The following is a description of a gene set: Genes predicted to be targets of miRBase v22 microRNA hsa-miR-4728-3p in miRDB v6.0 with MirTarget v4 prediction scores > 80 (high confidence targets). Human Gene Set: MIR4728_3P species: Homo sapiens from publication Chen Y, Wang X (PMID 31504780), and this is the list of marker genes: RORA, SMCHD1, ZNF655, KLHL2, SAMD12, PHLPP1, ZNF148, PTBP3, DMAC1, BDP1, PTCH1, PICALM, CNN3, GRM5, KICS2, SNX17, ZFP90, PRP4K, GPC6, ZSWIM6, PLXNA4, TRAM1, RAB6C, KCNA1, RYBP, TFPI, SEL1L, ZFAND5, HS3ST2, SCN1A, LRRN3, PABIR1, CDK19 (cyclin dependent kinase 19), GABRB3, OCIAD1, ZCCHC12 (zinc finger CCHC-type containing 12), UBE2K, TLL1, NDUFA2, NCOA1, ARMC2, CAB39, ZNF367, YWHAE, RALBP1, AMPD3, STK26, PGRMC2 (NCBI Gene Id 10424), ATPAF1, BTF3L4, SLC26A8, AMMECR1, KMT5B, TMED10, CACNA2D3, NCOA7, SLC9A6, SNX13, KRTAP7-1, CIDEB, CDIN1, FAM149B1, EMSY, CNOT4, MCHR2, MAPK1, PAK3 (NCBI Gene Id 5063, p21 (RAC1) activated kinase 3), ZNF189, LPP, KCNB1, TAF4, PPARGC1A, PRKACB (NCBI Gene Id 5567), GLCCI1, TNIP3, RABL2B, ZSCAN16 (NCBI Gene Id 80345), LZTFL1, WNK3, ZC3H12B, TXLNB (taxilin beta), ZNF75D, KIF14, CD22, CCDC28B, JARID2, ZNF449, PPP4R4, SEMA3A, YOD1, MIB1 (NCBI Gene Id 57534), TMEM132B, PAM, AUTS2, TBC1D22B, VAT1L, HACD2, PCLO (NCBI Gene Id 56630), APPBP2, RCOR1, LRP6, FAR1, FMO3, NAA15, RAPGEF5, FAXC, SNTG1, ATG2B, CD38 (CD38 molecule), RABL2A, TMEM60, PDS5A, MAGEL2, SH3BGRL2